The following is a description of a gene set: Human Gene Set: chr1p31 species: Homo sapiens, and this is the list of marker genes: DNAJB4, RN7SL488P, ROR1-AS1, LINC02796, PTGER3, NEDD8P1, DNAJC6, MIR4794, RPL13AP9, USP33, CACHD1, RNU4ATAC8P, ENSG00000252433, SGO1P1, LRRIQ3, ADGRL4, MIER1 (MIER1 transcriptional regulator), RPL29P5, MSH4, NEXN, LHX8, ASB17 (NCBI Gene Id 127247), MIR3117, ADGRL2, RNU6-1246P, FPGT, RN7SL854P, ZZZ3, HNRNPA1P64, MIR186, RNU6-371P, PIGPP2, CASP3P1, RN7SKP247, LINC01702, ARL5AP3, MIR3116-2, RNA5SP21, FPGT-TNNI3K, RNU4-88P, DNASE2B, DOCK7, PDE4B, NEXN-AS1, FUBP1, TTLL7, ROR1, ALG6, KRT8P21, DEPDC1-AS1, DNAI4, MGC27382, LINC02238, LINC02791, RN7SL130P, RNU6-622P, RPE65, JAK1, NFIA-AS2, RPS7P4, PATJ, PRKACB-DT, ATG4C, CTH, HNRNPCP9, RNFT1P2, RN7SL392P, RN7SL242P, WLS, SERBP1, ZRANB2-DT, EFCAB7, LINC01739, SRSF11, HSPE1P25, AK4, LEPROT, FOXD3, ADH5P2, DIRAS3, ACTG1P21, ZRANB2, ACADM (NCBI Gene Id 51779), RABGGTB, LINC01781, C1orf141, LINC01788, PIGK, RNU7-80P, RNU7-8P, DNAJB6P4, ENSG00000305461, MIR6068, RNU4ATAC4P, MIGA1, DLEU2L, GDI2P2, SNORD45C, PSAT1P3, AK5, TTLL7-IT1, DOCK7-DT, MIR7156, CFL1P3, RNU6-387P (RNA, U6 small nuclear 387, pseudogene), RNA5SP20, ELOCP18, RN7SL538P, SGIP1, MIR1262, NEGR1-IT1, ERICH3, RNU2-15P, ST6GALNAC3, HNRNPA3P14, INSL5, L1TD1, RN7SKP19, KANK4, CRYZ, LINC01362, LHX8-AS1, LINC01725, SLC44A5, ENSG00000225087, GNG12, MIR3671, CHORDC1P5, LINC02792, IFI44L, PDE4B-AS1, SAMD13, LINC03102, COX6A1P1, PIN1P1 (NCBI Gene Id 5301), RPL31P12, MTND2P30, ENSG00000199959, LAMTOR5P1, ARID3BP1, ENSG00000299211, RNU6-1031P, MED28P8, DLSTP1, GADD45A, IL12RB2, TYW3, RNA5SP23, MRPS21P1, LINC00466, RNU7-62P, PGM1, LINC01712, IL23R, MIR3116-1, LINC01707, TPI1P1, LRRC7-AS1, LINC01359, RNU7-123P, DYNLT5, IFI44, NFIA, RN7SL180P, SNORD45B, FOXD3-AS1, RNA5SP49, RN7SL370P, RPL7P10, RPL17P6, SLC35D1, ENSG00000231252, GNG12-AS1, LRRC53, CTBP2P8, USP1, GIPC2, TXN2P1, NSRP1P1, COX6CP13, ANGPTL3, LRRC7, HMGB1P18, ANKRD13C (NCBI Gene Id 81573), LRRC40, UBE2U, RNA5SP50 (NCBI Gene Id 106478992), NFIA-AS1, RPSAP65, RAVER2, COX6B1P7, RPS15AP7, LINC02567, RNU6-503P, TXNP2, ANKRD13C-DT, NEGR1 (neuronal growth regulator 1), LINC01758, LINC01361, RNA5SP22, ST6GALNAC5, RNU6-1102P, PTGFR, ENSG00000234953, PATJ-DT, SNORD45A, RPS29P7, ITGB3BP, RNU6-414P, TM2D1, RNU6-1176P, SLC2A3P2, RNU6-1177P, DEPDC1, RNU6-586P, LEPR, PRKACB, RNU6-161P, TNNI3K, ST13P20, ERICH3-AS1, UOX, MIR101-1, DNAJC6-AS1, ZRANB2-AS1, RNU6-809P, LINC01360